Given this list of marker genes TOLLIP, ADGRB3, ARPP21, NOTCH4, OMP, AURKAIP1, PDGFB, TPPP3, RPL39L, MEGF10, C2CD4A, KCNK2, MTSS2, PARVA (parvin alpha), TMEM182, NAP1L3, IRF2, BEST1, RPS26, GSTM2, MFSD6L, PNMA5, SCN4A, EDNRB, RNF186, ODF1, KLHL1, GP1BA, RIMKLB, SHISA2, NKX3-2, CRP, PRRT3, MERTK, CABP4, OXTR, DLX2, RAVER2, CDIPT, ARVCF, SPARCL1, GPR75, RASA4, HTRA1, RFX8, LMTK3, AKR1D1, MYBPC2, GPER1, ETV3L, ARHGEF10L, CD177, EIF1B, ADRM1 (NCBI Gene Id 11047), HJV, BTN1A1 (butyrophilin subfamily 1 member A1), OLIG1, TMEM210, MIR181D, SOWAHD (NCBI Gene Id 648756), ADGRF2P, TNFAIP6 (NCBI Gene Id 7130), SLC4A3, CDH23, TECRL, SPAG8, TBX19, ADRA1D, SOSTDC1, CYP7A1 (NCBI Gene Id 1581), PRM3, SUN5, LY6H, B3GALT4, FSTL5, CYP24A1, FNDC11, INSM1, TMCC2, SEC24C, TRIM72, VEGFD, TIGD3, TPSB2, MUC16, GRIA4, SAMD5, FAT1, CACNA1I, TNFRSF17, MFNG, POLR1C, PCDH17, CCL2, SH2D4A, CTDP1, RNPEPL1, NIPSNAP3A, HOMER2, PRIMA1, CACNA1H (calcium voltage-gated channel subunit alpha1 H), DEAF1, EFHD1, CDX1, PPY, GXYLT2, KCNJ10, PYY, SP2, HAPLN3, RPLP0, DLX5, TBX6, ARFGAP1, RNF123, PPARGC1B, FAM3D, KLHL10, PPIH, ADAMTS16, SNX11, LSM1, JAKMIP3, LOXHD1, CRTC3, MEP1A, DDAH2, ZBTB7C, C8orf48, NGRN, RFPL4B, CCDC97, IL17C, TTC38, SV2B, AMH, here is a description of the gene set: from publication Széles L, Keresztes G, Töröcsik D, Balajthy Z, Krenács L, Póliska S, Steinmeyer A, Zuegel U, Pruenster M, Rot A, Nagy L (PMID 19201860) Human Gene Set: GSE13762_CTRL_VS_125_VITAMIND_DAY5_DC_UP We have carried out global gene expression analysis to clarify the interrelationship between 1,25-dihydroxyvitamin D3 and differentiation-driven gene expression patterns in developing human monocyte-derived dendritic cells. Monocytes were treated with 10 nM 1,25-dihydroxyvitamin D3 or vehicle 14 hours after plating for 12 hours or 5 days. Monocytes, differentiating dendritic cells (+/-1,25-dihydroxyvitamin D3 for 12 hours) and immature dendritic cells (+/-1,25-dihydroxyvitamin D3 for 5 days) were harvested. This design allows one to identify genes regulated by differentiation and/or 1,25-dihydroxyvitamin D3 in human monocyte-derived dendritic cells. Genes up-regulated in dendritic cells (5 days): control versus 25-hydroxyvitamin D3. species: Homo sapiens